The following is a description of a gene set: Human Gene Set: MIR7855_5P from publication Chen Y, Wang X (PMID 31504780) studied in species Homo sapiens Genes predicted to be targets of miRBase v22 microRNA hsa-miR-7855-5p in miRDB v6.0 with MirTarget v4 prediction scores > 80 (high confidence targets)., and this is the list of marker genes: PDE4D, HDAC2, LIN7A, ANKRD50, FURIN, EPHB1, SLC35F2, VPS39, TMEM178B, SLC5A9, MYPN, RGS6, USP31, APPBP2, SNIP1, NAV1, NANOGNB, HOMER1, SMOC2, BPY2B, BNC2, ITGBL1, EEF1AKMT3, PCGF6, GOLGA2, IFT70A, MIER1, ZNF750, PAK3, GOLPH3, PRH2, PTGFRN, DPP3, LRBA, CENPBD1P, SCLT1, TECPR2, ADAM28, FAM81A (family with sequence similarity 81 member A), LPP, ATG13, PPP2R5D, VPS50, ADAMTSL1, FCGR1BP, ATG10, RPL10, STC1, TRABD2A, SIGMAR1, KLHL14 (NCBI Gene Id 57565), TRAT1, GSK3B, G2E3, RBM43, PRIM2, BDH2, TSC22D1, ZSWIM5, FGB, CBLB (Cbl proto-oncogene B), RORB, LRFN3, EIF5A2, ZNF316, TMEM213, PHACTR2, MED6, PLA2G4A, GPLD1, IMP4 (IMP U3 small nucleolar ribonucleoprotein 4), KCNH1, TNRC6B, TMSB15A, SPRR2D, BPY2, YTHDF3, BPY2C, SPATA3, PCDH19, INA, SYNJ2, LIAT1, LGR5